The following is a description of a gene set: studied in species Homo sapiens Genes down-regulated in comparison of lung tissue from wild type mice subjected to ozone for 24 h versus that from TLR4 deficient mice subjected to ozone for 24 h. from publication Bauer AK, Rondini EA, Hummel KA, Degraff LM, Walker C, Jedlicka AE, Kleeberger SR (PMID 21543283) Human Gene Set: GSE20715_WT_VS_TLR4_KO_24H_OZONE_LUNG_DN We previously identified toll-like receptor 4 (Tlr4) as a candidate gene responsible for ozone (O3)-induced pulmonary hyperpermeability and inflammation. The objective of this study was to determine the mechanism through which TLR4 modulates O3-induced pulmonary responses and to utilize transcriptomics to determine TLR4 effector molecules. C3H/HeJ (HeJ; Tlr4 mutant) and C3H/HeOuJ (OuJ; Tlr4 normal), mice were exposed continuously to 0.3 ppm O3 or filtered air for 6, 24, 48 or 72 hr. Affymetrix Mouse430A_MOE gene arrays were used to analyze lung homogenates from HeJ and OuJ mice followed using a bioinformatic analysis. Inflammation was assessed by bronchoalveolar lavage and molecular analysis by ELISA, immunoblotting, and transcription factor activity. TLR4 signals through both the MYD88-dependent and independent pathways in OuJ mice, which involves MAP kinase activation, NF-kappaB, AP-1, and KC. Microarray analyses identifiedTLR4 responsive genes for strain and time in OuJ versus HeJ mice (p<0.05). One significantly upregulated cluster of genes in OuJ were the heat shock proteins (Hspa1b; Hsp70), Hsp90ab1). Furthermore, O3-induced expression of HSP70 protein was increased in OuJ compared to HeJ mice following 24-48 h O3. Moreover, BAL polymorphonuclear leukocytes (PMN) and total protein were significantly reduced in response to O3 in Hspa1a/Hspa1btm1Dix (Hsp70-/-) compared to Hsp70+/+ mice (p<0.05). TLR4 signaling (MYD88-dependent), ERK1/2, AP-1 activity, and KC protein content were also significantly reduced after O3 exposure in Hsp70-/- compared to Hsp70+/+ mice (p<0.05). These studies suggest that HSP70 is involved in the regulation of O3-induced lung inflammation through the TLR4 pathway and provide evidence that HSP70 is an endogenous in vivo TLR4 ligand., and this is the list of marker genes: DYNLT4, HCCS, CPT2, ATP6V1E2, ZNF704, MPDU1, MT1E, CDC20, PPP1R21, SMAD4, ACOT9, TRPV2, KDM3A, ELK4, ARPC1B, ARL16, SLC6A8, SLC28A3, HINT1, ZNRF1, THSD1, AHSP, SLC30A7, RGS4, CCDC28A, PSMD4, USP12, CD27, ITGA2B, VWF, MARK2, COL4A1, PRKCD, HSD17B11, PDK4, CYP1B1, TJP3, MGAT4B, PTPN11, ESRP2, MTHFD1, MYOM1, SH2D3C, SFMBT2, MMP14, BTG2, HBEGF, MARCHF7, LDHB, PXMP4, FURIN, IMPDH1, NDE1, TTC28, LZTS2, SUMO3, WDR45, ARMCX4, NEURL4, C1QA, TRIM3, PARS2, ST3GAL5, UBR5, XPR1, NDUFS2, ARAP2, C11orf58, UBE2C, MTA1, LIPE, TMEM259, FOXJ2, ACADM, TFCP2L1 (transcription factor CP2 like 1), INPP5B (inositol polyphosphate-5-phosphatase B), FBN1, MIGA2, MBTD1, PABPN1, PQBP1, MAPKBP1, GADD45B, CYSTM1, RFTN2, DIAPH1, TRAF1, TUT1, IFITM10, CLN6, SAPCD1, NOS3, HMGCS2, IYD, LOX, ARL2BP, BABAM1, TBC1D23, IGFBP3, PLEKHG2, EGFL7, NME7, ARFGAP2, PLIN2, GJB6, ALOX12, ANGPTL4, PECAM1, SPNS1, BCLAF1, NIBAN2, USF2, NUDT9, IP6K1, BMP2, NIT1, CLOCK, CAMK2G, TPRA1, GABBR1 (NCBI Gene Id 2550), NRGN, KDM5D, EDC4, MED12, IER3, IFNGR1, ELN, LRRC49, LPXN, SLC15A2, ERBB3, GTPBP3, B9D2, GDPD1, KCMF1, PDLIM7, ABCA7, PSMD13, BIN3, MARCHF6, CDK16, CDKN1A, CENPF, SUCLG1, COL5A1, CLEC1B, HAL, CLIC1, ACTR1A, ECH1, CCR1 (C-C motif chemokine receptor 1), SLC10A6, ARRB1, NUMA1, SLC37A4, NBEAL2, LLGL1, ZNF740, FBXO15, CDO1, GRIN2C, ZIC3, TAP1, RGL2, SFTPD, ANAPC2, CHIA, CRIP2, POLR1A, LSR, TNK2, ARHGAP31, ECE1, ALDH3A1, SLC4A2 (NCBI Gene Id 96677), BMAL1, PNPLA7, RELN, KIF2A, TECPR1, PELO, TAB2, COG8, RFNG, TRRAP, APOE, ELK1, AKR1B10, UNC119B, TRIM25, LTBP2, LONP1, ARHGEF7, AP1M2, GDPD2, TOM1, MT2A, SLC35B3, BACH2, RRAD